Given this list of marker genes Cyp24a1, Nr1i2, Cyp27b1, Abcg5, Rarb, Abcg1, Cyp26a1, Nr1h3, Rara, Abcc3, Nr1i3, Cyp4b1, Cyp7a1, Abcd2, Cyp2e1, Cyp2b10, Ppara, Ppard (NCBI Gene Id 69050), Pparg, Cyp1a2, Cyp8b1, Rarg, Nr1h4 (nuclear receptor subfamily 1, group H, member 4), Abcb11, Vdr, Abca1, Abcc2, Abcd3, Abcb1a, Abcb4, here is a description of the gene set: Mouse Gene Set: WP_NUCLEAR_RECEPTORS_IN_LIPID_METABOLISM_AND_TOXICITY studied in species Mus musculus Nuclear receptors in lipid metabolism and toxicity